Given this list of marker genes RSPO3, DKK1, GPC3, NKD1, ABL1, ANKRD6, PLEKHA4, MLLT3, DAB2, here is a description of the gene set: Human Gene Set: GOBP_POSITIVE_REGULATION_OF_WNT_SIGNALING_PATHWAY_PLANAR_CELL_POLARITY_PATHWAY Any process that activates or increases the frequency, rate or extent of Wnt signaling pathway, planar cell polarity pathway. species: Homo sapiens